The following is a description of a gene set: Human Gene Set: MIR487A_5P from publication Chen Y, Wang X (PMID 31504780) studied in species Homo sapiens Genes predicted to be targets of miRBase v22 microRNA hsa-miR-487a-5p in miRDB v6.0 with MirTarget v4 prediction scores > 80 (high confidence targets)., and this is the list of marker genes: AKTIP, CLIP1, CTNNA1, SRSF2, RABIF, ATF1, RCC1L, AP1S3, ANKRD42, UTRN, SOX30, SORBS1, RAP2A, FRYL, TULP4, CXCL11, FNTA, TAFA4, ARHGAP32, EPB41L3, TSC22D2, GLDN, PDZRN3 (NCBI Gene Id 23024), MAGT1, ZC3H6, SPDYA, ZNF366, RINT1, NFATC1, ARID1A, MCPH1, COL4A3, LINC03103, NEDD4, ZNF544, SNX16, PLP1, SEMA3D, ZSWIM6, ANKS1A, GCLM, RAB5C, SLC12A2, PDSS1, DCLK1, PFN2, DIO2, PGGT1B, IDNK, TESK2, BIRC3, R3HDM1, CEACAM1, PTGER4, SERTAD4, GTF3C3, PRMT6, TDG, SLC39A9, BMP2, FRMD3, PDE8A, CWC15, MINAR1, FILIP1, HMBS, HGF, MOB3B, CBLN2, SH3BGRL, DYNLRB1, POLK, PLPPR5, SACS, FBXL3, SLC7A11, EPB41L2, MIER3, EMB, SP3, BAZ2A (NCBI Gene Id 23525), MTMR4, GFPT2, PARG, FMNL2, AKAP6, KIF13A, GLIPR1, SEPTIN11, IKZF4, OSTM1, OLFM3, RIMKLB, FAM199X, FMN1 (NCBI Gene Id 649014), PHYKPL, AR, FCGR2A, SLC25A30, ZC3H7A (NCBI Gene Id 54895), CCL28, AVPR1A, AMMECR1, ARID1B, CAMK4, SLC6A13, MFSD4B, CTSG